The following is a description of a gene set: Any process that results in a change in state or activity of a cell or an organism (in terms of movement, secretion, enzyme production, gene expression, etc.) as a result of a hydrostatic pressure stimulus. Hydrostatic pressure is the force acting on an object in a system where the fluid is at rest (as opposed to moving). The weight of the fluid above the object creates pressure on it. Mouse Gene Set: GOBP_RESPONSE_TO_HYDROSTATIC_PRESSURE studied in species Mus musculus, and this is the list of marker genes: Lrrc25, Pkd2, Pik3ca, Plec, Krt8, Ntrk1, Atp2b4